Given this list of marker genes POLR2L, POLR1D, POLR3H, POLR3E, POLR3A, POLR1C, POLR2H, POLR3G, CRCP, POLR3K, POLR2E, POLR3GL, POLR3F, POLR3D, POLR2K, POLR2F, POLR3C, POLR3B, here is a description of the gene set: Human Gene Set: REACTOME_RNA_POLYMERASE_III_CHAIN_ELONGATION RNA Polymerase III Chain Elongation studied in species Homo sapiens